The following is a description of a gene set: Down-regulated genes in both rectal and colon carcinoma compared to normal mucosa samples. studied in species Homo sapiens from publication Grade M, Hörmann P, Becker S, Hummon AB, Wangsa D, Varma S, Simon R, Liersch T, Becker H, Difilippantonio MJ, Ghadimi BM, Ried T (PMID 17210682) To characterize patterns of global transcriptional deregulation in primary colon carcinomas, we did gene expression profiling of 73 tumors using oligonucleotide microarrays. For 30 of the tumors, expression profiles were compared with those from matched normal mucosa samples. We identified a set of genes with highly significant deregulation between tumors and mucosa samples (P < 1e-7). A significant proportion of these genes mapped to chromosome 20 (P = 0.01). Seventeen genes had a >5-fold average expression difference between normal colon mucosa and carcinomas, including up-regulation of MYC and of HMGA1, a putative oncogene. Furthermore, we identified genes that were significantly differentially expressed between lymph node-negative and lymph node-positive tumors (P < 0.001), the functional annotation of which revealed a preponderance of genes that play a role in cellular immune response and surveillance. The microarray-derived gene expression levels of 20 deregulated genes were validated using quantitative real-time reverse transcription-PCR in >40 tumor and normal mucosa samples with good concordance between the techniques. Finally, we established a relationship between specific genomic imbalances, which were mapped for 32 of the analyzed colon tumors by comparative genomic hybridization, and alterations of global transcriptional activity. Previously, we had conducted a similar analysis of primary rectal carcinomas. The systematic comparison of colon and rectal carcinomas revealed a significant overlap of genomic imbalances and transcriptional deregulation, including activation of the Wnt/beta-catenin signaling cascade, suggesting similar pathogenic pathways. Human Gene Set: GRADE_COLON_AND_RECTAL_CANCER_DN, and this is the list of marker genes: GFI1, ZBTB4, CA5A, C2orf88, SIRPB1, STAT5A, TRPS1, SLC16A9, UBAP1, PDK4, JAM3, TIMM22, PARVB, CBS, LYPD3, PLPP1, MEF2D, HMGXB4, LDB2 (LIM domain binding 2), FAN1, NAT8L, CCR9 (NCBI Gene Id 2851), YY1AP1, CHST15, CD28, TGFBR3, SERTAD4, ZNF135, MYCN, SASH1, LRTOMT, PTPRZ1, CCDC71, SNCA, TYRP1, RERE, HIC2, GNPDA1, STAR, XPNPEP3, TBC1D27P, LRFN1, UGDH, ACTL8, SMIM14, TLN2, PRKACB, NAV1, CX3CR1, GTF3C4, CACNA2D2, CDK12, SOCS2, PCDHB5, PRRT2, KRT84, NR1H4, CPN2, UNC5B, DAP, SCAMP5, ADAMTSL4, NUDT11, B3GALNT1, GREB1, HAUS5, FABP7 (NCBI Gene Id 2173), SESN2 (NCBI Gene Id 83667), SLC30A3, LGALS2, CHST8, MITF, ITPKB, C14orf132, ST6GALNAC6, CYB5D1, ZNF787, GNA11, TOX2, COL4A5, SLC30A6, AOC2, GPR87, OSGIN2, FHL1, CFD, DHPS, GPC1, MSRA, AKR7A2, TLE4, SIX1, PGC (progastricsin), PLAC8, PARM1, SYNC, GGA1, TM9SF1, SPIN4, NR3C1 (nuclear receptor subfamily 3 group C member 1), PLD1, FKRP